Given this list of marker genes CDKN2D, MTCH2, BCL2L12, MIR132, RIPK3, PLAGL2, NOL3, NACC2, TP53, FBXW7, PLAUR, CD74, HDAC1, BAX, EPO, RPL26, IKBKG, BAD, TRAP1, PARK7, HERPUD1, APP, YBX3, HYOU1, TMBIM6, SYVN1, MIR16-1, PTTG1IP, ING2, BID, CCAR2, NHERF1, VNN1, GPX1 (glutathione peroxidase 1), SFRP2, DNAJA1, FZD1, WFS1, SELENOS, MMP9, CYLD, IL10, WNT1, MIR195, MIR27B, EI24, BBC3, BECN1, ENO1, P4HB, MIR133A1, BCAP31, MIR186, PTPN1, NOX1, FCGR2B, PRKRA, MIR17, ERP29, GRINA (glutamate ionotropic receptor NMDA type subunit associated protein 1), PYCR1, PARL, RPS7, S100A8, FIGNL1, DAPK2, PRODH, SNAI2, FYN, MIR21, MAPK7, BCLAF1, BOK, RRN3, PTPMT1, EIF2AK3, MDM2, PPIF, PIK3CB, MMP2, MIR92A1, ADCY10, STYXL1, RRM2B, USP15, SGMS1, TP53BP1, ATF4, FBXO7, NKX3-1, BCL2L1, TRIAP1, XBP1, CTNNB1, PPIA, TRIM32, FIS1, LCK, IL20RA, ATAD5 (ATPase family AAA domain containing 5), IVNS1ABP, RNF183, AKT1, SOD1, SRC (NCBI Gene Id 6714), LRRK2, EIF5A, CREB3, HTRA2, FLCN, PARP1, MUC1, ZNF385A, PMAIP1, INS, PIAS4, SFPQ, TAF6, PRKN, NCK2, URI1, MARCHF7, PDX1, DDIAS, ARMC10, TMEM161A, ACKR3, DDIT3, TXNDC12, CAV1, SKIL, BAG5, BCL2L11, DDX3X, TAF9B, HSPB1, HSPA1A, NONO, HNRNPK, CREB3L1, PINK1, MAP2K1, NCK1, FGF2, S100A9, MIF, MIR19A, BCL2, KDM1A, CXCL12, GATA4 (NCBI Gene Id 2626), USP47, PYCARD, MSX1, MAPK8IP1, SEPTIN4, CLU, ELL3, NME5, SIAH1, SOD2, MIR15A, SERINC3, NOC2L, UBB, GSDME, RACK1, MYC, MAGEA3, OPA1, MIR29B1, TIFAB (NCBI Gene Id 497189), TAF9, ARHGEF2 (Rho/Rac guanine nucleotide exchange factor 2), TPT1, RAD9A, TREM2, NFE2L2, RPS3, CD44, PTGS2, SNAI1, PTPN2, FBH1, MCL1, SIRT1, HIF1A, RTKN2, NUPR1, HELLS, UBQLN1, BDKRB2, IL19, TP73, here is a description of the gene set: Any process that modulates the frequency, rate or extent of intrinsic apoptotic signaling pathway. Human Gene Set: GOBP_REGULATION_OF_INTRINSIC_APOPTOTIC_SIGNALING_PATHWAY species: Homo sapiens